Given this list of marker genes SLC15A3, ZNF536, LGI4, MPZ, CHL1, HEYL, FAM78B, PRIMA1, TFAP2A, PLP1 (NCBI Gene Id 5354), ELOVL2, SLC35F1 (NCBI Gene Id 222553), MOXD1, S100B, LINC01505, SOX2-OT, NKAIN4, TSPAN11 (NCBI Gene Id 441631), CRYM, PTPRZ1, GABRA2, NKAIN3, NKAIN2, OLFML2A, CALHM2, CRYAB, IGSF11, KIRREL3, ADGRB1, NRXN1, ENTPD2, ADAM23, SOX10, WDR86, EGFLAM, CCN3, EDNRB, ABCA8, VGLL3, COL5A3 (collagen type V alpha 3 chain), LINC01192, ATP1A2, COL20A1 (collagen type XX alpha 1 chain), SNHG19, PPP1R1C, CDH19, AIF1L, TMEM71, here is a description of the gene set: Human Gene Set: DESCARTES_FETAL_STOMACH_ENS_GLIA species: Homo sapiens from publication Cao J, O'Day DR, Pliner HA, Kingsley PD, Deng M, Daza RM, Zager MA, Aldinger KA, Blecher-Gonen R, Zhang F, Spielmann M, Palis J, Doherty D, Steemers FJ, Glass IA, Trapnell C, Shendure J (PMID 33184181) The gene expression program underlying the specification of human cell types is of fundamental interest. The study authors generated human cell atlases of gene expression and chromatin accessibility in fetal tissues. For gene expression, the study authors applied three-level combinatorial indexing to >110 samples representing 15 organs, ultimately profiling ~4 million single cells. The study authors leveraged the literature and other atlases to identify and annotate hundreds of cell types and subtypes, both within and across tissues. Our analyses focused on organ-specific specializations of broadly distributed cell types (such as blood, endothelial, and epithelial), sites of fetal erythropoiesis (which notably included the adrenal gland), and integration with mouse developmental atlases (such as conserved specification of blood cells). These data represent a rich resource for the exploration of in vivo human gene expression in diverse tissues and cell types. Marker genes curated from the annotated cluster as represented in the Descartes Human Gene Expression During Development database.